The following is a description of a gene set: Human Gene Set: HP_ABNORMAL_ASTROCYTE_MORPHOLOGY species: Homo sapiens An abnormality of astrocytes. Abnormal astrocyte morphology, and this is the list of marker genes: MAPT, NUP54, GRN, CCM2, BRCA2, PMS2, TSC2, KRIT1, SQSTM1, APC, NUP62, ADAR, STRADA, VCP, AIFM1, TMEM106B, PIK3CA, NF1, CHEK2, ERCC6, MLH1, NF2, APC2, MTOR, SLC30A10, IDH2, TSC1, ERCC8, IFNG, TREM2, LAMA2, FGFR1, MSH3, PSEN1, IDH1, PDCD10, ERBB2, TP53, MSH6, CHMP2B, POLG, CDKN2A, PRNP, NSD1 (nuclear receptor binding SET domain protein 1), MDM2, MT-ATP6